Given this list of marker genes Shh, Plg, Sh3bp1, Stard13, Alox12, Pdpk1, Apoe, Csnk2b, Foxc2, Hdac5, Jcad, Mmrn1, Robo4, Tnf, Hdac9, Map2k3, Map2k5, Thbs1, Vash1, Mef2c, Krit1, Angpt4, Bcar1 (breast cancer anti-estrogen resistance 1), Sirt1, Prkd2, Acvrl1, Slit2, Fgf4 (NCBI Gene Id 14175), Tmsb4x, Smoc2, Svbp, Fgf2, Sec1 (secretory blood group 1), Hif1a, Ccbe1, Rhob, Efna1, Prkca, Sema5a, Emc10, Card10, Rock2, Hrg, Egf, Dll4, Atp5f1b (NCBI Gene Id 11947), Gdf2, Ets1, Epha2, Adgra2, Nfe2l2, Pik3cb, Gfus, Nos3, Anxa1, Bcas3, Rras, Pik3cg, Amotl1, Bmp4, Hmgb1, Sp1, Zfp580, Nr2e1, Fbxw7, Mir218-1, Gpld1, Synj2bp, Hdac7, Ceacam1, Tmem201, Cxcl13, Itgb3, Nus1, Notch1, Prcp, Spred1, Mir218-2 (microRNA 218-2), Ager, Gpi1, Wnt7a, Fut1, Atp2b4, Gab1 (NCBI Gene Id 14388), Meox2, Ptk2b, Gadd45a, Dcn, Prl7d1, Emp2, Serpinf1, Zc3h12a, Angpt2, Col18a1, Rin2, S2bpcox16, Pparg, Klf4, Rac1, Bsg, Prkd1, Cib1, Wnt5a, Plcg1, Fgfr1, Adamts9, Mmrn2, Bmp10, Itgb1bp1, Lcn2 (NCBI Gene Id 99344), Pik3c2a, Agt, Pdcd10, Fgf1, Ptprm, Nr2f2, Adam17, Rgcc, Srpx2, Fgfbp1, Stat5a, Pdcd6, Igf2, Gata3 (NCBI Gene Id 14462), Akt1, Met, Pik3r2, Angpt1, Cd40, Pdgfb, Dab2ip, Lgmn, Patz1, Calr, Grn, Tek, Abl1, Sash1, Snai2, Rhoj, Hmox1, Gata2 (NCBI Gene Id 14461), Hspb1, Glul (NCBI Gene Id 226521), Fgf16, Sp100, Nrp1, Ptn, Dicer1, Atoh8, Sparc, Ptgs2, Plk2 (NCBI Gene Id 20620), P2rx4, Foxp1, Dnaja4, Pik3cd, Prl2c2, Amot, Tbxa2r, Rhoa, Akt3, Bmper, Adora2b, Jup (NCBI Gene Id 16480), Plpp3, Apoh, Sema4a, Vegfa, Mecp2, Tgfbr3 (NCBI Gene Id 73753), Kdr, Anxa3, Tgfb1, Atp5f1a, Igf1, Map3k3, Flt4, Vegfc, Fgf18, Stc1, Adgrb1, Prox1, Nf1, here is a description of the gene set: Any process that modulates the rate, frequency, or extent of the orderly movement of an endothelial cell into the extracellular matrix to form an endothelium. studied in species Mus musculus Mouse Gene Set: GOBP_REGULATION_OF_ENDOTHELIAL_CELL_MIGRATION